The following is a description of a gene set: Binding to a phosphatidylinositol, a glycophospholipid with its sn-glycerol 3-phosphate residue is esterified to the 1-hydroxyl group of 1D-myo-inositol. studied in species Homo sapiens Human Gene Set: GOMF_1_PHOSPHATIDYLINOSITOL_BINDING, and this is the list of marker genes: SCARB1, SNX9, EEA1, SESTD1, ZFYVE1, SCIN (NCBI Gene Id 85477), PICALM, SNAP91 (NCBI Gene Id 9892), EPB41, ZFYVE16, FRMPD2, WDFY3, SNX10, ZFYVE9, WDFY1